The following is a description of a gene set: Human Gene Set: GSE43955_1H_VS_10H_ACT_CD4_TCELL_WITH_TGFB_IL6_UP Despite their enormous importance, the molecular circuits that control the differentiation of Th17 cells remain largely unknown. Recent studies have reconstructed regulatory networks in mammalian cells, but have focused on short-term responses and relied on perturbation approaches that cannot be applied to primary T cells. Here, we develop a systematic strategy – combining transcriptional profiling at high temporal resolution, novel computational algorithms, and innovative nanowire-based tools for performing gene perturbations in primary T cells – to derive and experimentally validate a temporal model of the dynamic regulatory network that controls Th17 differentiation. The network is arranged into two self-reinforcing and mutually antagonistic modules that either suppress or promote Th17 differentiation. The two modules contain 12 novel regulators with no previous implication in Th17 differentiation, which may be essential to maintain the appropriate balance of Th17 and other CD4+ T cell subsets. Overall, our study identifies and validates 39 regulatory factors that are embedded within a comprehensive temporal network and identifies novel drug targets and organizational principles for the differentiation of Th17 cells. Genes up-regulated in CD4 T helper cells Th17 treated with TGFB1 and IL6: 1h versus 10h. from publication Yosef N, Shalek AK, Gaublomme JT, Jin H, Lee Y, Awasthi A, Wu C, Karwacz K, Xiao S, Jorgolli M, Gennert D, Satija R, Shakya A, Lu DY, Trombetta JJ, Pillai MR, Ratcliffe PJ, Coleman ML, Bix M, Tantin D, Park H, Kuchroo VK, Regev A (PMID 23467089) studied in species Homo sapiens, and this is the list of marker genes: GSR, NME3, IRS1, VPS37B (VPS37B subunit of ESCRT-I), EEIG1, ALDH2, USP2, TSPAN32, CD81, CCNG2, MSH3 (NCBI Gene Id 4437), USF2, GPAT4, MAP2K7, AIMP1, EMCN, UTP3, MSX1, FASTK, SNX6, FAM3B, ARNT, GPATCH2, RNF7, CCR1, CLCN3, GLCE, CDC20, ADCY4, SGO1, GYG1, CRY2, NT5E, GOLM1, CEBPD, GPX2, GABARAP, SSU72 (NCBI Gene Id 79588), NPNT, CIDEB, FPR3 (formyl peptide receptor 3), LBR, DDX19A, RAB5IF, SLC2A8, SVIL, COX7A2L, HMGN5, COL9A2, KCNA7, FAM111A, PALD1, BCL7C, MYL3, NNT, CHCHD10, PRKAB1, HLA-DRA, NDUFB7, EIF4G3, SEMA3C, CAST, FPGS, HSD11B1, ZBTB2, NET1, TBR1, FKBP2 (NCBI Gene Id 2286), FASN, MCOLN2, LIMK2, ADRB3, TNPO1, NDUFB4, BHLHE40, LCP2, RAB24, CXCL2 (C-X-C motif chemokine ligand 2), PTH, NDUFS3, MSR1, HSP90AB1, TSSC4, AP2A1, HP, SIX3, BID, TMEM268, FH, CLTA, SWAP70, CCDC47, CS, MIOX, PACSIN1, NAA15, SUSD6, NCBP2AS2, RPS6KB1, SPDEF, WNT8A, NPY, CYP27B1, AP3S1, TYRP1 (tyrosinase related protein 1), S100A1, CDK11B, AVPR2, CACUL1 (CDK2 associated cullin domain 1), RPS29, GABRR1, UBE2C (NCBI Gene Id 11065), RGS10, HTATIP2, MYORG, NHSL3, DENND5A, NAP1L2, DPEP1, CD82, RMND5A, BRAP, ZNF358, ZNHIT2, KCTD9, FCGR2B, NUP107, FGF10, BPNT1, ATAD3A, NDST1, DTD2, SEC11C, RPSA (ribosomal protein SA), GEM, SAP30, OST4, SMPDL3A (NCBI Gene Id 10924), EPHX1, TDO2 (NCBI Gene Id 6999), GATD3, CLP1, PLXND1, GPR162, PCBP2, POU3F4, ROGDI, NOG, CSDE1, NUSAP1, ZNF799, SOCS1, GAB2, PLEKHO1, DNAJC10, TSEN34, COPS3, MFNG, EIF2AK1, HEXA, CCR2, UQCC5, FRK, TYROBP, NSG2, PFKFB1, LRP2, MADCAM1, HCCS, DHCR7, OXNAD1, ZNF740, IMPACT, PHB2, ENTPD1, RGS14, COMMD3, IL12RB1, RAD51AP1, REG1A, PLAA, CALR, PCCB, SEC14L1, ARHGAP39, WDTC1, GIPC1, SCG2, TOM1, RASAL3, ELOA, TFPI, GRK2, CNOT2, RTRAF, NDUFB5, AKAP8L, ZNF322, PEX11B